Given this list of marker genes BCAN, VCAN, NCAN, CHST3, CSPG4, DCN, BGN, CSPG5, here is a description of the gene set: Reactome Pathway: Defective CHST3 causes SEDCJD Carbohydrate sulfotransferase 3 (CHST3) transfers sulfate (SO4(2-)) to position 6 of N-acetylgalactosamine (GalNAc) residues of chondroitin-containg proteins resulting in chondroitin sulfate (CS), the predominant glycosaminoglycan present in cartilage. Defects in CHST3 result in spondyloepiphyseal dysplasia with congenital joint dislocations (SEDCJD; MIM:143095), a bone dysplasia clinically characterized by severe progressive kyphoscoliosis (abnormal curvature of the spine), arthritic changes with joint dislocations and short stature in adulthood. part of: Diseases associated with glycosaminoglycan metabolism species: Homo sapiens